Given this list of marker genes H2-M3, Cd248, Akr1c18, Prkci, Plcg1 (NCBI Gene Id 99130), Cd40lg, Ngfr, Thbs1, Ptpn1, Fasl, Cd40, Ccl12, Ager, Xbp1, Tgfb1, Col18a1, Rgcc, Pdcd4, Ano6, Bmp4, Gper1, Itga4, Ecscr, Cd160 (CD160 antigen), Foxo3, here is a description of the gene set: Any process that activates or increases the frequency, rate or extent of endothelial cell apoptotic process. studied in species Mus musculus Mouse Gene Set: GOBP_POSITIVE_REGULATION_OF_ENDOTHELIAL_CELL_APOPTOTIC_PROCESS